The following is a description of a gene set: Any process that modulates the rate, frequency, or extent of a mRNA catabolic process, the chemical reactions and pathways resulting in the breakdown of RNA, ribonucleic acid, one of the two main type of nucleic acid, consisting of a long, unbranched macromolecule formed from ribonucleotides joined in 3',5'-phosphodiester linkage. species: Homo sapiens Human Gene Set: GOBP_REGULATION_OF_MRNA_CATABOLIC_PROCESS, and this is the list of marker genes: LARP4B, MIR885, TNKS1BP1, FASTKD3, TENT5D, MIR130A, MIR27B, PAN3, SAMD4B, MIR517C, MIR424, FAM76B (family with sequence similarity 76 member B), FMR1, MIR329-1, GIGYF2, MIR133A1, MIR23A, MIR9-1, DAZ2, PKP1, MIR26B, MIR100, NANOS2, TAF15, CARHSP1, MIR501, YTHDF1, BOLL, APEX1, TRIM71, MIR326, CSDC2, MIR214, MIR663A, GTPBP1, MIR223, MIR1-1 (NCBI Gene Id 406904), MAGOHB (NCBI Gene Id 55110), THRAP3, MIRLET7A1, MIR320A, MIR181B1, HNRNPD, TRAF3IP2, MIRLET7C, TENT4A, TIRAP (TIR domain containing adaptor protein), TTC5, A1CF, FXR1, PLEKHN1, MIR544A, SERBP1, AXIN2, MIR34B, MIR520C, SAMD4A, DHX9, TNRC6A, SLC11A1, MIR20B, MIR93, PDE12, MIR191, RBM47, MIR495, ZC3HAV1, RNASEL, MIR199B, PCBP4, RBM38, MIR149, MIR140, TNRC6C, PRKCA, MIR29B1, CNOT10, MIRLET7B, CALCR, CNOT11, MIR145, ZAR1, TBRG4, MEX3D, SYNCRIP, MIR342, MIR423, DHX36, NORAD, NRDE2 (NCBI Gene Id 79790), MIR497 (NCBI Gene Id 574456), ROCK1, MIR302A, PKP3, TOB1, FXR2, MIR18A, MIR203A, CNOT7, MIR337, DAZ1, PAIP1, MIR562, DIS3, MIR608, MIR106B, TRAF5, MIR142, MIR125B1, NANOS1, MIR340, ELAVL1, EIF4A3, PABPN1L, PUM2, MIR125A, MIR206, CACNG7, RBM8A, IREB2, FTO, CASC3, MIR302C, MIR137, MAPKAPK2, NOCT, LARP1B, VIP, PUM1, RBM10, PABPC4, PRKCD, TENT5C, MIR517A, MIR20A, MIR181C, DAZ3, METTL16, VIM, SECISBP2, PATL2, ALKBH5, IGF2BP1, EIF4ENIF1, YTHDF2, POLR2G, RIDA, HNRNPU, CAPRIN1, GTSF1, SENP1, MIR483, IGF2BP2 (insulin like growth factor 2 mRNA binding protein 2), MIR181D, MOV10, PARN, AGO2, NPM1, CELF1, MIR146A, CPEB3, MAGOH, IKBKE, ANGEL2, MIR212, AKT1, MAPK14 (NCBI Gene Id 1432), CNOT6L, MIR491, MIR98, E2F1, MYD88, TUT4, HNRNPA0, MIR665, MIR485 (NCBI Gene Id 574436), HNRNPAB, MIR625, GDNF (glial cell derived neurotrophic factor), CNOT1, DAZ4, SCGB1A1, ZFP36L1, ROCK2, QKI, MIR24-1, MIR211 (microRNA 211), MIR200B, UPF3A, MIR708, ELAVL4, NBAS, PIAS4, MIR543, MIR210, NANOS3, FUS, YTHDF3, DCP1B, RC3H2, MEIOC, FASTKD2, MIR19B1 (NCBI Gene Id 406980), MLH1, CNOT6, SRSF1, MIR519A1, CNOT8, DIS3L2, APOBEC1, TENT4B, LARP1, RBM24, MIR181A2, MIR365A, TUT7, MIR30B, CNOT3, PRR5L, CNOT2, NICOL1, MIR96, ZC3H14, MIR106A, RBM33, TENT5A, ARID5A, YBX1, DCP2, NT5C3B, KHSRP, CSDE1, IGF2BP3, UPF1, PNLDC1, DCPS (decapping enzyme, scavenger), MIR564, PAN2, AGO3, TENT5B, PATL1, TNRC6B, FBLL1, FASTK, BTG2, MIR128-1, DAZL, ZFP36, MIR103B1, MIR151A, MIR135B, MIR130B, AGO4, PIWIL2, MIR204, MIRLET7E, PIWIL1, LSM1, MIR655, MIR190B, CIRBP, ZC3H12D, AGO1, MIR193A, FASTKD5, TRAF2, MIR27A, MIR185, YBX3, PABPC1, RC3H1, HNRNPC, RBM46, FASTKD1 (FAST kinase domains 1), CNOT4, MIR4286, MIR519D, MIR19A, MIR200C, DHX34, MIR373, TARDBP, METTL3, PNPT1, DCP1A, METTL14, ZC3H12A, ZFP36L2, CNOT9, DND1, MIR486-1, MIR195, MIR192